The following is a description of a gene set: Genes predicted to be targets of miRBase v22 microRNA hsa-miR-12124 in miRDB v6.0 with MirTarget v4 prediction scores > 80 (high confidence targets). studied in species Homo sapiens from publication Chen Y, Wang X (PMID 31504780) Human Gene Set: MIR12124, and this is the list of marker genes: STARD13, GM2A, LRP2, GRIN2A, SCN9A, TRAPPC11, NEK3, PABIR1, SLC30A7, ST6GALNAC3, ITGA4, RAD9B, ACER3, ATG5, DDX10, KL, CLVS1, CUL4B, NHLH2, ZBTB1, CXCL10, CNTN1, UBE2H, SMC3, GTF2A1, HECW2, GTF2H1, PRR27, SLC7A11, ABTB3, CCNG2, EOGT, ELMOD2, CSN2, EVI5, LARP4, RBM12, NUFIP2, CREBZF, CA8, RFX3, IQGAP2, TAF7L, DNM3, ADHFE1, GSTCD, MORC3, UPRT, PPP4R4, LINC03104, PPIP5K2, C2CD5, GABRA2, SYNPO2L, RSPO4, AGL, ENSG00000277067, CNBD2 (NCBI Gene Id 140894), TRAPPC2, SEC63, KLHL21, RRP15, TBL1XR1, ZNF572, GRM3, B4GALT1 (NCBI Gene Id 2683), ITGA8, CTBS, SERBP1, SEMA3A, TP53INP1, GABRA5, SV2C, SALL4 (spalt like transcription factor 4), RAB3GAP2, BACH1, KCTD12, ZNF280B, SLITRK2, ETAA1, SGIP1, SESTD1, ABCA13, PTAFR, SAR1B, MAP3K20, PRKACB, COL4A4, HORMAD1, RAD1, HPCAL4, SNHG32, APCS, KRAS, NFIB, TRIP11, TOX3, ZBTB14, SOX7, NDUFAF4 (NADH:ubiquinone oxidoreductase complex assembly factor 4), RICTOR, HTR2B, VAMP7, UBE2E1, PPP3R1, WBP11, PPM1E (NCBI Gene Id 22843), TENT2, FBXO11, STN1, ZNF706, CFL2, HFE, NEBL, LACC1, MTFMT, ZNF148, PDXDC1, ASH1L, GNAQ, A1CF, ZNF24, GRIA3, FGF2, TMEM106B, MOB1A, FBXO43, BTF3L4, NUP43, NCL, PSMG2, GABPB2, RAB11FIP1, DUS4L, SGMS1, KIF3A, PTER, FBXL5, SCG3, LMBR1, LAMP2, BRAF, LY6K, BCKDHB, SRP72, NETO1, EFCAB14, SLC18B1, SHROOM3, FXYD6, CNOT6, SCAI, BNIP2, GPR158, MAML3, CNTN4, ZEB2, ADAM28, COL25A1, UBE3D, RANBP6, SRGAP2B, ZKSCAN2, FZD5, BAZ2B (bromodomain adjacent to zinc finger domain 2B), PEX1, LRRC19, BBOX1, ATP10D, TBXAS1, TUB, RNF14, DYNLT3, CCNE2, C3orf70, USP24, SPAG1, BMAL2, AIDA, THSD7A, LINGO1, USP32, ZBTB20, CFAP47, GSTM4, LMBRD2, PAK3, ZBTB41, MINDY2, LRCH1, FNBP4, SPDYA, PLSCR4, ADAMTS6, TERF1, MGAT4A, TMEM237, ERRFI1, CAB39L, PHIP, TATDN2, ARPP19, CKAP5, HYCC2, UBTD2, NIN, RNF144A, YWHAQ, POLR3G, KIF5B, MAP3K5, NCOA6, CDK6, TM9SF3, KPNA4, SORCS3, PDLIM5, UQCRC2, MAGT1, CACNB4, CBLB, SLC30A4, NECTIN2, TRAF6, SOCS4, CERKL, ZNF704, TAPT1, EIF4A2, HDAC9, AAK1, DLG4, PRLR, SAR1A (NCBI Gene Id 56909), UQCRB, SNX13, PTBP3, HS2ST1, GDAP2, LINC03105, MXD1, PIKFYVE, ASF1A, TMEM215, KLF12, SUN1, MCMBP, TENT4A, CTSV, TFPI2, ANKIB1, RBM14, FAM199X, FRMD7, NR2C2AP, GALNT18, HOOK3, KDM2B, GABRB2, MEIOC, PDZRN4, SHISA6, LUC7L3, UBE2B, HLCS, NEMF, NSL1, PHB2, KCNT2, UNC5B, IRAK1BP1, FUT9, PWP1, PABIR3, SLC6A2, AQP9, PURB, HECTD1, SMAD2, ORC4, CFAP299, NMD3, PCYT1A, BTC, NHERF4, PLPPR4 (NCBI Gene Id 9890), ECT2, ANKRD45, SAMSN1, ZNF430, TFCP2L1, SS18L1, KIF21A, TMEM41B, PERP, PIR, CLVS2, ZNF772, FLVCR2, UNC5C, MRE11, SGCZ, DDX52, FAT4, HLA-DRA, KLHL24, EXD1, TMEM30A, SOS1, TAT, GNB1, ARID1B, EML4, PWWP3B, TXNDC16, SRGAP2C (NCBI Gene Id 653464), KPNA3, USP46, MAX, RABIF, LMNB1, FAAH2, DKK2, LAMP3, CHAC2, INO80D, ACTR3B, ARSJ, GRIK4, NR3C1, ZBTB5